The following is a description of a gene set: studied in species Homo sapiens Human Gene Set: GOBP_B_CELL_CHEMOTAXIS The directed movement of a B cell guided by a specific chemical concentration gradient. Movement may be towards a higher concentration (positive chemotaxis) or towards a lower concentration (negative chemotaxis)., and this is the list of marker genes: XCL1, HSD3B7, CH25H, CYP7B1, PIK3CD, CXCL13, GAS6, PTK2B